The following is a description of a gene set: Human Gene Set: HP_ABNORMAL_PIGMENTATION_OF_THE_ORAL_MUCOSA An abnormality of the pigmentation of the mucosa of the mouth. Abnormal pigmentation of the oral mucosa studied in species Homo sapiens, and this is the list of marker genes: MTX2, C4B (NCBI Gene Id 721), ATRX, MECP2, PTPN22, TNIP1, TP53, CR2, USP8 (ubiquitin specific peptidase 8), ITGAM, JAZF1, ABCC6, XYLT1, TNFSF4, USP48, IRF5, STAT4, TNFAIP3, KRT14, NR3C1, SPP1, CDH23, UBE2L3, STK11 (NCBI Gene Id 6794), IRAK1, IL10, TREX1, IGHG1, CTLA4, FCGR2B, HLA-DRB1, ABCD1, PDCD1, DNASE1, PXK, KIAA0319L, C4A, FCGR3B, XYLT2, BANK1, BLK, BRAF (NCBI Gene Id 673), ETS1, TLR7